The following is a description of a gene set: species: Mus musculus Mouse Gene Set: GOBP_NATURAL_KILLER_CELL_PROLIFERATION The expansion of a natural killer cell population by cell division., and this is the list of marker genes: Emp2, Kctd9, Slamf6 (SLAM family member 6), Elf4, Flt3l, Il12b, Ptpn22, Lep, Jak2, Tyk2, Cd244a, Il15, Il23a, Stat5b, Gm36723, Il18, Slamf1, H2-T23